The following is a description of a gene set: species: Homo sapiens part of: Metabolism of steroid hormones Reactome Pathway: Glucocorticoid biosynthesis Cortisol, the major human glucocorticoid, is synthesized in the zona fasciculata of the adrenal cortex from pregnenolone. Pregnenolone is converted to 17alpha-hydoxyprogesterone in two reactions, both catalyzed by 3-beta-hydroxysteroid dehydrogenase/isomerase. 17Alpha-hydroxyprogesterone is hydroxylated by CYP21A2 to form 11-deoxycortisol, which in turn is converted to cortisol by CYP11B1. The conversion of the active steroid hormone, cortisol, to inactive cortisone occurs in many tissues, notably the liver., and this is the list of marker genes: HSD3B1, CYP17A1, HSD3B2, CYP21A2, HSD11B1, SERPINA6, CYP11B1, CYP11B2, HSD11B2, POMC